The following is a description of a gene set: from publication Chen Y, Wang X (PMID 31504780) Genes predicted to be targets of miRBase v22 microRNA mmu_miR_7056_3p in miRDB v6.0 with MirTarget v4 prediction scores > 80 (high confidence targets). species: Mus musculus Mouse Gene Set: MIR_7056_3P, and this is the list of marker genes: Slc35a2, Arf6, Gcnt4, Trim39, Pla2g4c, Gyg1, Lhfpl6, Zfp551 (zinc finger protein 551), Brwd3, Sp9, Heyl, Zfp629 (zinc finger protein 629), Klf4, Lrrc4c, Acp3, Ascl1, Prlr, Atp8b2, Spdye4b, Cpd (NCBI Gene Id 12874), Fkbp14, Mapk9, Ythdf3, Extl1, Msx2, Reep2